The following is a description of a gene set: Aside from Myc-activating translocations characteristic of plasmacytomas (PCT), little is known about genetic factors and signaling pathways responsible for the development of spontaneous B-cell lineage lymphomas of mice. Here, we characterized the transcriptional profiles of PCT, centroblastic diffuse large B-cell lymphomas (CBL), and high-grade splenic marginal zone B-cell lymphoma (MZL++) using high-throughput quantitative reverse transcription-PCR. Expression profiles of CBL and MZL++ were strikingly similar and quite unlike that of PCT. Among the genes expressed at significantly higher levels by PCT were a number involved in NOTCH signaling, a finding supported by gene set enrichment analyses of microarray data. To investigate the importance of this pathway, NOTCH signaling was blocked in PCT cell lines by treatment with a gamma-secretase inhibitor (GSI) or transduction of a dominant-negative mutant of MAML1. These treatments resulted in reduced expression of NOTCH transcriptional targets in association with impaired proliferation and increased apoptosis. GSI treatment of transformed plasma cells in a primary PCT also induced apoptosis. These results integrate NOTCH activation with oncogenic signaling pathways downstream of translocated Myc in the pathogenesis of mouse PCT, two signaling pathways also implicated in development of human multiple myeloma and T-cell lymphoblastic lymphoma. species: Mus musculus Cluster 6 of genes distinguishing among different B lymphocyte neoplasms. from publication Shin DM, Shaffer DJ, Wang H, Roopenian DC, Morse HC 3rd (PMID 19010892) Human Gene Set: SHIN_B_CELL_LYMPHOMA_CLUSTER_6, and this is the list of marker genes: ID3, IL1B, HOXA1, PTGS2, HOXA7, IFNB1, CDX4, S100A8, SIX3, LMO2, SOCS1, WNT1